Given this list of marker genes TUBB6, TUBAL3, NSF, DYNC1LI2, DCTN5, ARF1, TUBB2A, COG1, TUBA8, GOSR1, TUBA1A, ARF4, GBF1, BET1L, GOLGB1, ACTR1A, COG5, COPA, COPG2, KDELR2, SPTBN2 (NCBI Gene Id 6712), NAPB, CAPZA2, CAPZA1 (capping actin protein of muscle Z-line subunit alpha 1), DCTN1, TUBB8, DCTN2, TUBA1B, COG7, DYNC1I1, TUBA3D (NCBI Gene Id 150778), DYNC1I2, USO1, SPTA1, SPTBN4, TUBB1, SPTB, CAPZB, INS, ACTR10, COG4 (NCBI Gene Id 25839), ARF5, NAPG, DCTN6, NAPA, TUBB4A, TMED7, COG3, SPTAN1, COPE, GORASP1, GOSR2, KDELR1, DYNC1LI1, TMEM115, RAB1A, DCTN3, TUBB8B, FOLR1, ARFGAP1, SPTBN5, TUBB4B, ANK2, TMED9, DYNLL1, ARCN1, TMED10, SPTBN1, ANK3, RAB1B, BET1, TUBA4A, YKT6, COG6, STX5, TUBB2B, TUBA1C, ARFGAP2, TUBB3, DCTN4, DYNLL2 (NCBI Gene Id 140735), COG2, ARF3, CAPZA3, GOLGA2 (NCBI Gene Id 2801), TUBA4B, COG8, CD55, ANK1, COPZ1, TMED3, CD59, COPG1, DYNC1H1, ARFGAP3, TMED2, COPZ2, TUBA3E, TUBA3C, COPB1, KDELR3, COPB2, here is a description of the gene set: COPI-mediated anterograde transport species: Homo sapiens Human Gene Set: REACTOME_COPI_MEDIATED_ANTEROGRADE_TRANSPORT